The following is a description of a gene set: An immune response-regulating cell surface receptor signaling pathway that contributes to the endocytic engulfment of external particulate material by phagocytes. species: Mus musculus Mouse Gene Set: GOBP_IMMUNE_RESPONSE_REGULATING_CELL_SURFACE_RECEPTOR_SIGNALING_PATHWAY_INVOLVED_IN_PHAGOCYTOSIS, and this is the list of marker genes: Appl2, Myo1g, Nos2, Fcer2a, Appl1